Given this list of marker genes PTAFR, FCGR2B, NDFIP2, CLDN1, PALS1, PIK3R6, MX2, CRLF3, RNF19B, EEIG2, MITF, CXCL1, GRIA1, RND1, PNRC1, PPFIBP1, ATG9A, IL12B, TRPS1, SKIL, MYOT, SRFBP1, NFKBIE, RNF2, CD38, SLC49A4, HS3ST3A1, ADHFE1, MAPK6, NOTCH2, MVP, FRMD6, FOXP1, KBTBD2, RRS1, HOOK3, RGL1, HCK, TRIM13, GBP5, ST3GAL1, MAP3K5, DLGAP4, DNAJA2, TNFAIP2, ABR, SDE2, CCNL1, COP1, GSAP, ABTB2, SCN4A, TANK, CCR9, TBC1D2B, CCRL2, RNF14, MED13L, PTPRE, DUSP16, BTBD7, NFKBIA, ERICH6, HCAR2, CLN5, ICAM4, AGO3, IKZF5, NFKBIZ, EHD1, KCNA3, CD274, EDN1, HIVEP3, DOCK10 (NCBI Gene Id 9714), GCH1, MAPKAPK2, NINJ1, RAPGEF2, RBM7, AGPAT4, MOCS1, MALT1, UBE2F, ALPI, RC3H1, SBDS, RNF6, SLC4A7, IRAK2, PTGER4, HBS1L, LMBRD1, NCKAP5, CTRL, CCDC88B, NCK1, CLEC2D, NFKB1, TFEC, IGSF6, BTG2 (BTG anti-proliferation factor 2), GTF2F1, CCL7, PLAUR, CD44, NFE2L2, FLRT3, IRF1, MEFV, NUP54, PTGS2, DSE, STIM2, NLRP3, PDYN, MEX3C, CYBB, FAM20C, PLEK, NALF2, TNFSF15, TMEM168, MCOLN2, IFT57, MAMLD1, KLF7, NFKBIL1, RHBDF2, RSAD2, ICAM1, GBP2, MED21, PLSCR1, RFFL, DTWD1, ICOSLG, TRAF1 (TNF receptor associated factor 1), GTF2B, CASP4, MYD88, CERS6, REL, REXO4, SAMD9L, AHR, ANP32A, SEPTIN11, GPD2, GNA13, RHOU, CCL5, FCRLB, SAMSN1, GBP3, SQSTM1, NOD1, TMEM200B, LMO4, RELB, RALGDS, HEATR6, CCL4, PIK3R5, TREH, CD14, OLR1, NUPR1, PDE4B, PSMD10, here is a description of the gene set: species: Homo sapiens Human Gene Set: GSE7768_OVA_ALONE_VS_OVA_WITH_LPS_IMMUNIZED_MOUSE_WHOLE_SPLEEN_6H_DN Genes down-regulated in spleens from mice immunized with ova peptides alone versus those immunized with LPS as adjuvant. An unresolved issue in immunology is the extent to which inflammatory effects are needed for robust T cell responses. In this study, mice were immunized by iv injection using either high toxicity lipopolysaccharide (LPS) or low toxicity monophosphoryl lipid A (MPL) as adjuvant. Six hours after iv immunization, whole spleens were harvested and gene expression was measured in unfractionated splenic populations of cells. The analysis indicated that the low toxicity adjuvanticity of MPL was associated with TLR4-mediated signaling that was biased to the TRIF branch of TLR4, while LPS generated balanced MyD88 and TRIF-associated outcomes. from publication Mata-Haro V, Cekic C, Martin M, Chilton PM, Casella CR, Mitchell TC (PMID 17569868)